Given this list of marker genes Mtrr, Cyb561d1, Steap1, Heph, Cyb561d2, Steap4, Cyb561a3, Hephl1, Frrs1, Mmachc, Cp, Steap3, Fxn, Cybrd1, Fth1, Steap2, Ftmt, here is a description of the gene set: species: Mus musculus Mouse Gene Set: GOMF_OXIDOREDUCTASE_ACTIVITY_ACTING_ON_METAL_IONS Catalysis of an oxidation-reduction in which the oxidation state of metal ion is altered.